The following is a description of a gene set: Human Gene Set: chr6p24 species: Homo sapiens, and this is the list of marker genes: RPL7L1P20, PAK1IP1, AMD1P4, HIVEP1, HNRNPLP1, TMEM14C, SLC35B3, NEDD9, ADTRP, PHACTR1, TMEM14B-DT, TMEM170B, DSP-AS1, THAP12P5, RPS26P29, RPL29P1, TBC1D7, RNA5SP203, RNU6ATAC21P, EDN1, ENSG00000310201, ENSG00000233656, ENSG00000303868, TFAP2A-AS2, ELOVL2, TFAP2A, PAGE4P1, ENSG00000299686, IDH1P1, RPL15P3, EEF1E1, ENSG00000215022, BLOC1S5, GCNT2, RPL21P62, TXNDC5, RNU1-11P, ENSG00000232234, MIR5689 (microRNA 5689), PIP5K1P1, LINC00518, DSP, TMEM14B (transmembrane protein 14B), LINC02522, MRPL48P1, HULC, RPS3P4, BLOC1S5-TXNDC5, SSR1, TFAP2A-AS1, RN7SKP293, OFCC1, SNRNP48, C6orf52, SUMO2P12, RNU1-64P, ELOVL2-AS1, BMP6, GCNT2P1, EEF1E1-BLOC1S5, RREB1, CAGE1, GCM2, ENSG00000207419, MAK, ACCSLP1, ERVFRD-1, RIOK1, LINC02530, SMIM13, RPL21P63, RPL7AP36, SYCP2L